Given this list of marker genes Atp1a2, Dusp5, Per2, P2rx1, Gja5, Ptger3, Avpr2, Bmpr2, Rbfox2 (RNA binding protein, fox-1 homolog (C. elegans) 2), Adra1b, Tbxa2r, Hif1a, Edn2, Smad6, Add3, Dbh, Adra2a, Tbxas1, Uts2r, Abl1, Trpm4, Casr, Adra1a, Fgb, Arhgap42, Fga, F2r, Map2k1, Adra2b, Tacr1, Zdhhc21, Itgb1, Faah, Mmp2, Rhoa, Ahr, Hrh1, Stub1, Mtnr1b, Avpr1b, Fgg, Apln, Pde5a, Dock5, Dock4, Cacna1c, Mgll, Gja1, Icam1, Hmgcr, Htr2c, Ptgs2, Kcna5, Adra1d, Adra2c, Agtr1b, Chrm3, Shc1 (src homology 2 domain-containing transforming protein C1), Nos1, Drd1, Htr2a, Ptgs1, Svep1, Cx3cl1, Hrh2, Smtnl1, Lep, Atp2b1, Cysltr1, Akt1, Cav1, Npy1r, Itga4, Wdr35, Itga9, Oxtr, Cd38, Avpr1a, Snta1, Avp, Ace (NCBI Gene Id 11421), Edn1, Alox5, Htr7, Htr1a, Adm, Chga, Egfr, Asic2, Pdgfb, Agtr1a, Grk2, Edn3, here is a description of the gene set: studied in species Mus musculus Mouse Gene Set: GOBP_REGULATION_OF_VASOCONSTRICTION Any process that modulates the frequency, rate or extent of reductions in the diameter of blood vessels.